Given this list of marker genes ITIH4, C8G, IGFALS, IGF1, SLC27A5, ORM1, CYP2C8, CYP1A2, HSD17B6, MAT1A, CYP2C9, RDH16 (NCBI Gene Id 8608), SDS, NNMT, HGFAC, ADH1C, SLC22A1, ORM2, CYP2E1 (NCBI Gene Id 1571), APCS, CYP2A6, F2, HRG, HAMP, SERPING1, APOC4, here is a description of the gene set: Neighborhood of IGF1 insulin-like growth factor 1 (somatomedin C) in the GNF2 expression compendium Neighborhood of IGF1 species: Homo sapiens Human Gene Set: GNF2_IGF1